Given this list of marker genes Psmb6, Psmb10, Psmb5, Psmb9, Psmb8, Psmb11, Psmb7, Prss50, Tasp1, here is a description of the gene set: Catalysis of the hydrolysis of internal peptide bonds in a polypeptide chain by a mechanism in which the hydroxyl group of a threonine residue at the active center acts as a nucleophile. species: Mus musculus Mouse Gene Set: GOMF_THREONINE_TYPE_ENDOPEPTIDASE_ACTIVITY